The following is a description of a gene set: from publication Chen Y, Wang X (PMID 31504780) Human Gene Set: MIR4469 Genes predicted to be targets of miRBase v22 microRNA hsa-miR-4469 in miRDB v6.0 with MirTarget v4 prediction scores > 80 (high confidence targets). species: Homo sapiens, and this is the list of marker genes: FAM131A, SUPT3H, GSK3B, OXSR1, CLCN3, GRSF1, PPP1R21, VPS26B, ARK2C, MSI2, TRIQK, KDM4C, SOX11, SRSF6, EMX2, NTM, MYOCD, VPS33B, TNFRSF13B, MSX2, CACNA1E (calcium voltage-gated channel subunit alpha1 E), PPP3CA, KLHDC7A, C14orf132, CDK18, NAALADL2, WDR43, RFX5, SEC14L5, SMG7, FAM170A, FOXK1, FAM199X, SYNPO2L, GOSR1, AGAP1, CAPN15, RPA3, VCF1, GRAMD1B, FAM114A2, PSIP1, FRMD5, DHX33, TMEM132B, ZBTB20, KCNQ3, PICK1, GPR176, RABEP1 (rabaptin, RAB GTPase binding effector protein 1), PALM2AKAP2, DDX55, SASS6, SLC25A16, STK35, ADGRL1, MAP2K3, TMEM38B, EDN1, CD300A, PRCP, TRIM67, LSAMP, CACNG8, SPTLC3, PPP1R16B, PPFIA2, SINHCAF, BST2, NR6A1, TMEM121B, UCK1, STK32C, PPP1R1A, ASIC1, ZNRF2, FGF11 (NCBI Gene Id 2256), DTX4, ZNF691, HOXB7 (NCBI Gene Id 3217), TAOK2, SETD7 (NCBI Gene Id 80854), MAP1A, HOPX, UPF1, ERMN, RASL10B, MAP7D3, MIDEAS, SPATA13, NOL9, TAF1L, KCNA7, JARID2, GTPBP10, MAP2K4, HTR7, PLCB3, GPRC5B, ATXN1L, PTPRG, NCAM1, BARX2, LMO2, DESI2, FAM78B, VDAC3, TMEM39A, SDHC, TMOD2, IL1R1, RBL2 (NCBI Gene Id 5934)